The following is a description of a gene set: from publication Chen Y, Wang X (PMID 31504780) Human Gene Set: MIR3129_5P Genes predicted to be targets of miRBase v22 microRNA hsa-miR-3129-5p in miRDB v6.0 with MirTarget v4 prediction scores > 80 (high confidence targets). studied in species Homo sapiens, and this is the list of marker genes: CREBRF, UBQLN1, NLRP1, LAMP3, PHLPP2, C2orf49, CCDC85C, RAP2A, FAM199X, ADAMTS3 (ADAM metallopeptidase with thrombospondin type 1 motif 3), ZNF217, SLC24A2, PROSER1, CHAD, MED12L, PPP4R2, ERBB4, NACC1, RUNX1, MCFD2, COL12A1, NAA25, SDC2, EMC1 (ER membrane protein complex subunit 1), CDK17, ZHX1, PTPRZ1, BCAR3, CELSR2, ASAP2, CDK7, DNHD1, WFDC8, EBF1, SMIM8, FXR1, MAP3K4, PAWR, SOS2, GORAB, LPAR4, PTPN3 (NCBI Gene Id 5774), ACVR2B (NCBI Gene Id 93), HIC2, ITGA3, PIK3CB, CSRP2, FN1, CYP1B1, SERPINE2, TAB2, KIAA0319L, KDM3A, DCBLD2, ADRB1, TAOK1 (NCBI Gene Id 80214), NECTIN2, VAMP3, ITGA8, ADAM10, RPS6KA6, ANKRD61, MECP2, NOVA1, TBX3, RFX3, RB1, EPG5, SH3GLB1, SLC44A5, ALX4, ACVR2A, CYB5R4, ANKRD44, SINHCAF, WDR47, ADD3 (adducin 3), SP1 (NCBI Gene Id 6667), AEBP2 (AE binding protein 2), PLAG1, PCDH7, PNRC1, ATRX, SCD, APLF, NIBAN1, SLC20A2, NET1, SLC39A10, MAP3K5, PON2, KLHL3, ARL15, DNMT3A, CPEB4, ETNK1, PLEKHH1, RBM47, LRP2, PSD2, TUBGCP3, DEPDC1B (DEP domain containing 1B), PRPF40A, CBLL1, ESRP1, TGIF2, FUBP1 (far upstream element binding protein 1), AMZ2, APLP2, PAK4, CEP85L, KDM6A, LRRC1, RAPH1, PPP2R5E, GRK3, MS4A7, PLCB1, PTPRC, CTNNA2, C9orf40, NEDD4, CXADR, ITGA6, ITGB8, KDM5A, NLK, LIN28B, ITPK1, GALNT7, SEMA3A, TPPP, NTRK2, G3BP2, CD2AP, SLITRK6, ARHGEF3, IFFO2, PDE4B, TMEM62 (NCBI Gene Id 95722), MVB12B, VPS33A, LLGL2, RP1, ATAD1, ADAMTSL3, QKI, FGF7, CDNF, AK4, KATNBL1, NID2, MPP7, GNA12